The following is a description of a gene set: Any process that modulates the frequency, rate or extent of male gonad development. studied in species Mus musculus Mouse Gene Set: GOBP_REGULATION_OF_MALE_GONAD_DEVELOPMENT, and this is the list of marker genes: Sema3a, Zfpm2, Insl3, Eif2s3y, Sry, Dmrt1, Cited2 (NCBI Gene Id 17684), Nr5a1, Asmt, Sox9, Dhx37, Wt1, Wnt4